The following is a description of a gene set: species: Homo sapiens Human Gene Set: GOBP_MEMBRANE_REPOLARIZATION_DURING_ATRIAL_CARDIAC_MUSCLE_CELL_ACTION_POTENTIAL The process in which ions are transported across a membrane such that the atrial cardiomyocyte membrane potential changes in the direction from the positive membrane potential at the peak of the action potential towards the negative resting potential., and this is the list of marker genes: KCNJ3, KCNN2, KCNJ5, KCNQ1, FLNA, KCNA5, MIR328